Given this list of marker genes SOX9, GATA2, NFKBIZ, BAX, RAC3, COL14A1, TUBA1A, IL7, FOSL2, NOS3, RAC1, CORO1A, PRDM14, PTH, F2R, GNAT2, KMT2A, KRAS, ELP6, PRDX5, P2RX7, ILDR2, BCL2, LIPA, NOTCH1, VPS54, VEGFA, GIGYF2, MINAR2, CCR2, AKT3, SMO, GATA1, PTPN11, IL20RB, FH, EPG5, CSF1, KLHL10, SASH3, XIAP, BRINP1, RPA1, here is a description of the gene set: studied in species Homo sapiens Any biological process involved in the maintenance of the steady-state number of cells within a population of cells in a tissue. Human Gene Set: GOBP_HOMEOSTASIS_OF_NUMBER_OF_CELLS_WITHIN_A_TISSUE